The following is a description of a gene set: Human Gene Set: WAMUNYOKOLI_OVARIAN_CANCER_GRADES_1_2_UP studied in species Homo sapiens PURPOSE: To elucidate the molecular mechanisms contributing to the unique clinicopathologic characteristics of mucinous ovarian carcinoma, global gene expression profiling of mucinous ovarian tumors was carried out. EXPERIMENTAL DESIGN: Gene expression profiling was completed for 25 microdissected mucinous tumors using Affymetrix U133 Plus 2.0 oligonucleotide microarrays. Hierarchical clustering and binary tree prediction analysis were used to determine the relationships among mucinous specimens and a series of previously profiled microdissected serous tumors and normal ovarian surface epithelium. PathwayAssist software was used to identify putative signaling pathways involved in the development of mucinous LMP tumors and adenocarcinomas. RESULTS: Comparison of the gene profiles between mucinous tumors and normal ovarian epithelial cells identified 1,599, 2,916, and 1,765 differentially expressed in genes in the cystadenomas, LMP tumors, and adenocarcinomas, respectively. Hierarchical clustering showed that mucinous and serous LMP tumors are distinct. In addition, there was a close association of mucinous LMP tumors and adenocarcinomas with serous adenocarcinomas. Binary tree prediction revealed increased heterogeneity among mucinous tumors compared with their serous counterparts. Furthermore, the cystadenomas coexpressed a subset of genes that were differentially regulated in LMP and adenocarcinoma specimens compared with normal ovarian surface epithelium. PathwayAssist highlighted pathways with expression of genes involved in drug resistance in both LMP and adenocarcinoma samples. In addition, genes involved in cytoskeletal regulation were specifically up-regulated in the mucinous adenocarcinomas. CONCLUSIONS: These data provide a useful basis for understanding the molecular events leading to the development and progression of mucinous ovarian cancer. Genes up-regulated in mucinous ovarian carcinoma tumors of grades 1 and 2 compared to the normal ovarian survace epithelium tissue. from publication Wamunyokoli FW, Bonome T, Lee JY, Feltmate CM, Welch WR, Radonovich M, Pise-Masison C, Brady J, Hao K, Berkowitz RS, Mok S, Birrer MJ (PMID 16467078), and this is the list of marker genes: SELENOI, ELL2, ELL3, GGT1, GALNT3, LLGL2, MUC1, PBLD, PDIA4, EDEM3, RNF128, KLF5, CD164, ERBB3, F11R, HINT3, LYZ, MYO6, KCNK1, STK39, PDIA5, GALNT7, GALNT4, ESRP1 (epithelial splicing regulatory protein 1), GOLPH3, C5orf24, STXBP5, HEPH, CMPK1, BAG1, FDFT1, CYP51A1, EPCAM, MLLT6, CD24, RASSF6, TMEM30B, CXXC5, VSIG10, ARSD, TM9SF3, SAR1B, ATP5ME, MAP7, CCNDBP1, SEC24A, UNC5CL, MYO10, KDELR2, PDIA3, PIK3R2, GRTP1, SH3BGRL2, SH3RF1 (NCBI Gene Id 57630), ITGA6, CTBP2, SYT13, NME7, ELOVL6, SH2D4A, CHMP4C, SGSM3, CTSE, JPT1, FOXQ1, GFPT1, SANBR, ATP8B1, MESD, CPD, SYTL2, IRAK2, GPATCH4, ATP5MK, FZD5, ABCC3, CLDN23, SEC22B, ABHD17C, GDA, GPR160, ACBD5, SLC35D2, DOK4, TMED4, BRI3BP, MECOM, ABHD2, PERP, TMEM181, TPD52, PHLDA2, ECT2, CA2, ASPHD2, BZW2, NUDT15, C3orf52, EPHB4, RASEF, TSPAN8, AGR3, PLS1, NQO1, SLC39A14, SLC39A11, GNPNAT1, DDAH1, ETFB, IQGAP2, ETNK1 (ethanolamine kinase 1), QSOX1, FRK, CASK, PDZD8, ATP1B1, NET1, ARHGAP12 (NCBI Gene Id 94134), ABCD3, RALA, ARPC5L, SFN, COX7A2, FNIP2, TNPO1, OCIAD2, GFUS, H3-3A, SLC35A2, DSC2, HIGD1A, PLAC8, TOX3, CEBPG, SFXN1, S100A14, LRRC8B, SLC35A3, MAL2 (mal, T cell differentiation protein 2), GMDS